Given this list of marker genes Cttnbp2, Septin7, Actg1, Dbn1, Myo6, Actb, Ppp1r9a, Myh10 (myosin, heavy polypeptide 10, non-muscle), Cttn, Nefm, Actn4, Myo5a, Itpka, Nefl, Fam107a, Myo5b, Nefh, Filip1, Ina, Sptbn2, Myo9b, Kptn, Abi2, Actn2, Marcks, Itsn1, here is a description of the gene set: studied in species Mus musculus Mouse Gene Set: GOCC_POSTSYNAPTIC_CYTOSKELETON The portion of the cytoskeleton contained within the postsynapse.